The following is a description of a gene set: species: Homo sapiens Genes down-regulated during acute viral infection in KLRG1 low CD8 T cells: wildtype versus FOXO1 knockout. The forkhead O transcription factors (FOXO) integrate a range of extracellular signals including growth factor signaling, inflammation, oxidative stress and nutrient availability, to substantially alter the program of gene expression and modulate cell survival, cell cycle progression, and many cell-type specific responses yet to be unraveled. Naive antigen-specific CD8+ T cells undergo a rapid expansion and arming of effector function within days of pathogen exposure, but in addition, by the peak of expansion, they form precursors to memory T cells capable of self-renewal and indefinite survival. We used microarrays to determine whether FOXO1 broadly affects effector and memory differentiation, and to what extent FOXO1 determines the program of memory T cell gene expression. Human Gene Set: GSE46025_WT_VS_FOXO1_KO_KLRG1_LOW_CD8_EFFECTOR_TCELL_DN from publication Hess Michelini R, Doedens AL, Goldrath AW, Hedrick SM (PMID 23712431), and this is the list of marker genes: ACLY, SCAMP1-AS1, YTHDF3, WEE1, PLEKHA1, ENSG00000290964, KCNN3, MED21, ALG13, EIF4A2, PDS5B, HMMR, G3BP2, FAM76B, SMCO4, LYRM7, BLOC1S6, PDCL, RWDD3, CXorf38 (chromosome X open reading frame 38), ANOS1, EZR, CTAGE11P, ADNP, EXPH5, MORC3, LINC02609, FRMD7 (NCBI Gene Id 90167), HIPK1, ZNF879, FAM3C, ELMOD2, PRKAA1, TAS2R5, ZNF22-AS1, RBM18, WASIR2, PDE10A, TMEM168, CMPK2 (cytidine/uridine monophosphate kinase 2), C1orf56, UNC13C, TRA2B, WIPF1, ZW10, LRRC58 (NCBI Gene Id 116064), ARFIP1, TTF2, SEC24A, MBLAC2, ZRANB2, COL4A5, CCDC183, CREBBP, AGFG1, GRK3, FOXN2, PTGR2, PEX11A, FAM199X, MVB12B, HCP5, PSMD12 (proteasome 26S subunit, non-ATPase 12), TCERG1, TMEM52B, PRNP, FTO, PAX8-AS1, MIR3142HG, BNIP2, OR8D2 (olfactory receptor family 8 subfamily D member 2), RFK, GSKIP, TLE6, CARNMT1, ANP32E, TRAF3IP3, MDH1B, ZFAND6, SALL1, GPR65, PCMTD2, BNC1, LINC00608, DCTN4, PPP1CC, ANKRD44, CLASP2, GFPT2, COPB1 (NCBI Gene Id 51664), ACADM, ATF2, ABCC9, YY1, HGD (NCBI Gene Id 727722), TNFRSF10A-DT, COPS8, CCR10, DSC1, VPS4B, SNORA37, PTPN11, SUMO3, SPCS3, CSNK1G3, SENP7, OTC, RANBP9, ANAPC16, AKAP6, CASP8, CRYBG1, VDAC3, PPM1B, FBXO30, ZCCHC8, SSR1, SHISA2, RNF25, PSG1, MICALL1, CLSTN2 (calsyntenin 2), CCRL2, SMARCA2, HSPH1, YIPF4, MSC-AS1, MORN4, LLPH, RC3H1, ANO6, DENND6A, MYO5A, PHF6, FMO9P, PDE7A, FAM13B, WDR90, TK2, RIOX1, TYROBP, GRM8, NPM1, ZNF281, ACTR3, PSORS1C2, LINC01003 (long intergenic non-protein coding RNA 1003), DCLRE1A, TM2D1, TRIM22, ISCA1, FAM117A, PDE12, TMEM266, NXNL2, SCYL2, BMI1, PIGW, TOMM70, IMPA1, SPDL1, TMEM158 (NCBI Gene Id 25907), HNRNPUL1, ZBTB3, ARL6IP1, PLSCR3, TUT4, CMTM6 (NCBI Gene Id 55487), SCAI, NUDT4, DYNC1I2, ACER3, FAM117B, ELK3, LAMP2 (lysosomal associated membrane protein 2), ATXN1, TTN, CDC27, ZNF572, SUV39H2, SLAIN2, CD46, RNF19A, MCMDC2, YES1, HOXA5, CDKN2C, MTFR2, HSPB9, TRMT5, TMEM230, THAP12, DDX52, NIPAL1